Given this list of marker genes Cwc22, Sub1, Fyn, Ssbp3, Dcun1d4, Lonrf2, Srp54b, Xpo7, Mtpn, Homez, Traf3, Ccl22, Cyfip1, Ntng1, A1cf, Nfasc, Esr2, Cpd, Zfp704, Map7d3, Larp1 (NCBI Gene Id 73158), Wdr76, Notch4, Yipf3, Astn2, Rmdn3, Tbx18, Kdm1b, Slc16a2, Nid2, Hapln1, Zbtb21, Fam107a, Wnt4, Pigh, Samd4, Gpr146, Lrrc71, Zdhhc15, Tmem252, Fyttd1, Prlr, Igf1, Gpc6, Cdip1, Gnas, Brca1, Eogt (NCBI Gene Id 58893), Itgb1, Pde1b, Fam124a, Slc38a2, Pcgf5, Ap1s2, Rimbp2, Map6, Cpsf6, Ctbs, Eya4, D430041D05Rik, Jade3, Ccer1, Kcne4, Slc25a40, Casd1, Kif1b, Tbx4, Ptma, Nebl, Bmpr1a, Slc7a1, Syde2, Rab30, Trim39, Ppm1g, Galnt3, Tent5d, Slu7, Pex12, Efr3b, Zzef1, Tsc1, here is a description of the gene set: studied in species Mus musculus from publication Chen Y, Wang X (PMID 31504780) Genes predicted to be targets of miRBase v22 microRNA mmu_miR_7034_3p in miRDB v6.0 with MirTarget v4 prediction scores > 80 (high confidence targets). Mouse Gene Set: MIR_7034_3P